Given this list of marker genes Atp6ap1, mt-Atp8 (mitochondrially encoded ATP synthase 8), Atp5po, Dmac2l, Tmem199, Atp6v1g1, Atp6v1e2, mt-Atp6, Atp6v1b2, Atg5lrt, Atp6v1c1, Atp6v1d, Atp6v1h, Atp5f1d, Atp5f1e, Atp6v0a4, Atp5mk (NCBI Gene Id 66477), Atp6v0e, Atp6v0a1, Ccdc115, Atp6v1g2, Atp6-ps (NCBI Gene Id 100503946), Atp5f1b, Atp6v0b, Atp6v1f, Atp5mc2, Atp5me, Atp5f1a, Tcirg1, Atp6v1b1, Atp6v0e2, Atp6v0d1, Spaar, Atp6ap2, Atp5mj, Atp6v1c2, Atp6v1a, Atp5mc1, Atp6v0a2, Atp5mc3, Atp6v1g3, Atp5pd, Atp5pb, Atp5mg, Rnasek, Atp6v1e1, Atp6v0d2, Atp6v0c, Atp6ap1l, Atp5f1c, Atp5pf, Atp5mf, here is a description of the gene set: studied in species Mus musculus Mouse Gene Set: GOCC_PROTON_TRANSPORTING_TWO_SECTOR_ATPASE_COMPLEX A large protein complex that catalyzes the synthesis or hydrolysis of ATP by a rotational mechanism, coupled to the transport of protons across a membrane. The complex comprises a membrane sector (F0, V0, or A0) that carries out proton transport and a cytoplasmic compartment sector (F1, V1, or A1) that catalyzes ATP synthesis or hydrolysis. Two major types have been characterized: V-type ATPases couple ATP hydrolysis to the transport of protons across a concentration gradient, whereas F-type ATPases, also known as ATP synthases, normally run in the reverse direction to utilize energy from a proton concentration or electrochemical gradient to synthesize ATP. A third type, A-type ATPases have been found in archaea, and are closely related to eukaryotic V-type ATPases but are reversible.